Given this list of marker genes ATF2, ELK3, ELK1 (ETS transcription factor ELK1), JUN, HSF1, NFATC3, JUND, TP53, here is a description of the gene set: Human Gene Set: TURJANSKI_MAPK8_AND_MAPK9_TARGETS Examples of transcription factors whose activities are regulated by MAPK8 and MAPK9. from publication Turjanski AG, Vaqué JP, Gutkind JS (PMID 17496919) The mitogen-activated protein kinases (MAPKs) are a family of serine/threonine kinases that play an essential role in signal transduction by modulating gene transcription in the nucleus in response to changes in the cellular environment. They include the extracellular signal-regulated protein kinases (ERK1 and ERK2); c-Jun N-terminal kinases (JNK1, JNK2, JNK3); p38s (p38alpha, p38beta, p38gamma, p38delta) and ERK5. The molecular events in which MAPKs function can be separated in discrete and yet interrelated steps: activation of the MAPK by their upstream kinases, changes in the subcellular localization of MAPKs, and recognition, binding and phosphorylation of MAPK downstream targets. The resulting pattern of gene expression will ultimately depend on the integration of the combinatorial signals provided by the temporal activation of each group of MAPKs. This review will focus on how the specificity of signal transmission by MAPKs is achieved by scaffolding molecules and by the presence of structural motifs in MAPKs that are dynamically regulated by phosphorylation and protein-protein interactions. We discuss also how MAPKs recognize and phosphorylate their target nuclear proteins, including transcription factors, co-activators and repressors and chromatin-remodeling molecules, thereby affecting an intricate balance of nuclear regulatory molecules that ultimately control gene expression in response to environmental cues. species: Homo sapiens